The following is a description of a gene set: studied in species Homo sapiens Human Gene Set: HP_CENTRAL_HYPOVENTILATION Central hypoventilation, and this is the list of marker genes: NDUFAF2, RET, LBX1, PHOX2B, CRLS1, TPM2, DCTN1, HOXA1, ASCL1, MYPN, TPM3, MECP2